Given this list of marker genes Nceh1, Stat5a (NCBI Gene Id 20850), Otc, Rph3a, Ptprf, Pnp2, Pnp, Mthfd2, Pde2a, Rela, Slc34a2 (NCBI Gene Id 52185), Sh2b3, G6pc1, Gng12, here is a description of the gene set: Mouse Gene Set: GOMF_PHOSPHATE_ION_BINDING species: Mus musculus Binding to a phosphate ion.